The following is a description of a gene set: Mastinib is a class II tyrosine kinase inhibitor that targets mutant and wild-type FGFR3, PDGFR and c-KIT. Masitinib, like imatinib, is effective in inhibiting the activity of juxtamembrane mutant forms of KIT, but is ineffective against many of the mutations in the activation loop and ATP-binding cleft of the receptor. part of: Drug resistance of KIT mutants Reactome Pathway: Masitinib-resistant KIT mutants species: Homo sapiens, and this is the list of marker genes: KIT